The following is a description of a gene set: RHOG GTPase cycle studied in species Homo sapiens Human Gene Set: REACTOME_RHOG_GTPASE_CYCLE, and this is the list of marker genes: LETM1, KALRN, KTN1, CAV1, ARHGAP5, DEPDC1B, VAV3, ARHGAP39 (NCBI Gene Id 80728), LAMTOR1, LBR, MCF2L, DIAPH3, VAMP3, OPHN1, ARHGDIB, VAPB, LEMD3, IQGAP2, ARHGEF16, MPP7, EMD, ANKLE2, NDUFS3, CYFIP1, STBD1, DOCK2, MCAM, ELMO2, PAK4, HSPE1, ITSN1, PLD1 (NCBI Gene Id 5337), EPHA2, ARHGDIG, SHMT2, VAV1, GARRE1, DOCK5, RHOG, TRIO, MAP3K11, TFRC, ARHGAP35, CDC42, ARFGAP3, ARHGAP21, NDUFA5, ITGB1, PGRMC2, VAV2, ARHGAP32, RAB7A, VANGL1, DOCK1, ARHGDIA, STX5, ERBIN, PAK2, ARHGEF26, ARHGAP1, LMAN1, PLEKHG3, ESYT1, YKT6, ARHGEF5, MCF2, DOCK4, TMPO, PIK3R1, VRK2, CDC42EP1, PREX1, DSG2, DOCK3